Given this list of marker genes NADK2, SLC26A2, CASD1, PDIK1L, IL16, RAB3D, FTSJ3, NXT1, ZC3H14, NICN1, ENKD1, RBM4B, ASB13, MCAT, H2AX, GTPBP3, HENMT1, TAMM41, RRS1, FEN1, FRAT2, RDH13, LINC00957 (long intergenic non-protein coding RNA 957), TACC3, BCL7A, DCAF13, RCOR3, WDR12, SLC19A1, INTS5, PPAT, EEF2, DTWD1, MTA1, NIFK, OGFOD2, WIPI2, ZBTB48, MAP3K3, SGSM2, NOP14, RNF166, TMEM223, TBC1D24, DAAM1, NCKAP5L, MOAP1, SUV39H1, MYG1, OGFOD1, CCT6A, ZNF641, PLD6, GINS3, SMARCA4, DCP1B, POLR3B, SWSAP1 (SWIM-type zinc finger 7 associated protein 1), MBTD1, IMPDH2, TMED8, SHPK, POP7, WRAP53, MRPL45, AIMP2, SPHK2, CPSF4, ZYG11B, RFC3, CRTAP, NATD1, ALKBH2, NCAPD3, ASTE1, ZNF275, ZNF630 (zinc finger protein 630), FAM21EP, SLC25A44, PIP4P2, WASH3P, PHF23 (NCBI Gene Id 79142), ZNF383, STARD7, OTULIN, EFTUD2, UBXN6, ZBED3, MSTO1, TCHP (trichoplein keratin filament binding), POLRMT, YAE1, KIAA1143, KDM5B, UTP11, PRDM15, LETM1, ZNF544, NOA1 (NCBI Gene Id 84273), MTAP, ZNF420, NUDT16, KIAA2013 (NCBI Gene Id 90231), GLIS2, MMACHC, DCAF4, PHF13, AATF, KCTD6, SSBP3, PIP4K2B, MTX3, EXOSC2, DEPTOR, SLC25A38, CLUAP1, THAP11 (THAP domain containing 11), PPP1CC, LRRC8A, PSTPIP1, B4GALT7, PEX5, ZBTB46, DCAF16 (DDB1 and CUL4 associated factor 16), SLC7A6OS, HNRNPA0, ZSCAN16, C2orf68, NAT10, RTL6, DUSP7, C15orf61, MRFAP1L2, ATRIP, DDX51, DEF6, PXYLP1, LPCAT3, SLC30A4, BRD3, CLPX, SYK, DHRS13, TSN, NAA40, MPLKIP, GTF3C5, SATB2, ZBTB8A, KDM4B, PSMF1, YPEL3, LRRC47, SNAP47, CSTF2, ZNF398, TMEM94, ORAI3 (ORAI calcium release-activated calcium modulator 3), EPS15L1, SLC27A1, CROT, RSAD1, ZCCHC24, SPDL1, CNOT6, ZNF672, UBE4B, HAUS6 (HAUS augmin like complex subunit 6), IRAG2, DBF4, TBL2, LANCL1, MAP1A, FBRSL1, SHQ1, RETREG3, KAT6B, ZBTB26, POC1A, BCR, ZNF252P, KLHDC2, GAS2L3, THOC5, SHB, NOL9, ZNF791, PIGW, ZNF77, MLXIP, UBAP2, VKORC1L1, FAM234B, SPSB3, ATXN3, BCAS3, MDC1, here is a description of the gene set: from publication Ceppi M, Clavarino G, Gatti E, Schmidt EK, de Gassart A, Blankenship D, Ogola G, Banchereau J, Chaussabel D, Pierre P (PMID 19943945) Human Gene Set: GSE14000_UNSTIM_VS_4H_LPS_DC_UP species: Homo sapiens Dendritic cells (DCs) are the sentinels of the mammalian immune system and they undergo a complex maturation process mediated by activation upon pathogen detection. Recent studies described the analysis of activated DCs by transcriptional profiling, but translation regulation was never taken in account. Therefore, the nature of the mRNAs being translated at various stages of DC activation was determined with the help of translational profiling, which is the sucrose gradient fractionation of polysomal-bound mRNAs combined to microarrays analysis. Total and polysomal-bound mRNA populations were compared in immature (0h) and LPS-stimulated (4h and 16h) human monocyte-derived DCs with the help of Affymetrix microarrays. Biostatistical analysis indicated that 296 mRNA molecules are translationally regulated during DC-activation. The most abundant biological process among the regulated mRNAs was protein biosynthesis, indicating the existence of a negative feedback loop regulating translation. Interestingly, a cluster of 17 ribosomal proteins were part of the regulated mRNAs, indicating that translation may be fine-tuned by particular components of the translational machinery. Our observations highlight the importance of translation regulation during the immune response, and may favour the identification of novel gene clusters or protein networks relevant for immunity. Our study also provides information on the possible absence of correlation between gene expression and real protein production in DCs. Genes up-regulated in comparison of dendritic cells (DC) before and 4 h after LPS (TLR4 agonist) stimulation.